The following is a description of a gene set: species: Mus musculus Any process that reduces cell size. Mouse Gene Set: GOBP_NEGATIVE_REGULATION_OF_CELL_SIZE, and this is the list of marker genes: Tsc2, Cav3, C1qtnf9, Akt1s1, Rdx, Pten, Rhoa, Deptor, Mfn2, Ucn, Akt1, Mtor, Cfl1, Tsc1